Given this list of marker genes PELI1, STAP1, ECE1, SP140, SLC2A3, IER2, MYCBP2, ST6GAL1, PTP4A1, CDC42SE1, PLCG2, IRS2, TMEM131L, IGHM, LYST, CD79B, MS4A1, PDLIM1, ARHGAP25, ZFP36L1, CHMP7, NT5E, NR4A2, DGKD, RASGRP3, DUSP1, IGKC (NCBI Gene Id 3514), ABLIM1, FCMR, IGLJ3, CCR6, GSAP, PMAIP1, YBX3, TRIO, TTC9, MKNK2, BACH1, ALOX5, LIMD2, EVL, CLEC2D, BACH2, MTSS1, HLA-F-AS1, APOL3 (NCBI Gene Id 80833), HMGB2, IGHD, TAF1D, SWAP70, EIF1B, MRGBP, ADAM28, MSN, BCL2, RYK, MBD4, PARP12, AIM2, SP140L, PIK3C2B, HES1, HLA-F, PAX5, TUBA4A, MACF1, JUNB, BACE2 (beta-secretase 2), SYPL1, HK2, P2RX5, CD69, HIF1A, ATP2B1, BTG1, NOC3L, IGLV1-44, RAB8B, PLAAT4 (NCBI Gene Id 5920), NCK2, CD48, IFT57, MYC, FAM111A, PAPOLA, RESF1, DDIT3, PIK3IP1, DPEP2, LAT2, PRDM2, ZNF318, BANK1, SCPEP1, SHMT2, RAB30, IL4R (interleukin 4 receptor), PPFIBP2, IGKV3-20, SMCHD1, TUBA1A, RHOH, BCL2A1, ADD2, WWC3, PKIG, EZR, KLHL2, CD22, LY86 (NCBI Gene Id 9450), RAB29, FCER2 (NCBI Gene Id 2208), NLRP1, ISG20, PHTF2, CD72, RRAS2, KCNA3, FOXO1, CXCR5, TRAF5, GVINP1, CDKN1B, LAPTM5, CD37, CD83, TNFRSF13B, QRSL1, IL24, CD79A, BASP1, TENT5C, TRAK2, PDK1, EIF2AK3, P2RY10, PTPRC, KLF7, HLA-DOB (NCBI Gene Id 3112), CHST2, SYNPO, TANK, PLEKHF2, IER5, CD55, SIPA1L3, CKAP2, PWP1, RHOB, FCGR2C, JUN, CDC42EP3, TBL1X, RASA3, SLC35F2, BMP2K, ELF1, IGHG1, PPP1CC, SP100, ARID5B, CDK14, CHD7, FCGR2B, MARCKS, MMD (NCBI Gene Id 23531), USP6NL, NFKBIA, ADAM8, TPD52, FCRL2, PTPN12 (NCBI Gene Id 5782), SH3BP5, ARHGDIB, CR1, LINC00623, CD24, CD19, KDM7A, TSC22D3, TRIB2, KLF2, PLEKHA2, IGKV1D-13, BIRC3, POU2AF1, ABCB4, UBXN1, PIKFYVE, EGR1, SNX2, BMS1P20, TXNIP, CEMIP2, ICAM3, CLIC4, here is a description of the gene set: Human Gene Set: GSE29618_BCELL_VS_PDC_UP species: Homo sapiens Genes up-regulated in comparison of B cells versus plasmacytoid dendritic cells (pDC). from publication Nakaya HI, Wrammert J, Lee EK, Racioppi L, Marie-Kunze S, Haining WN, Means AR, Kasturi SP, Khan N, Li GM, McCausland M, Kanchan V, Kokko KE, Li S, Elbein R, Mehta AK, Aderem A, Subbarao K, Ahmed R, Pulendran B (PMID 21743478) Systems vaccinology has emerged as an interdisciplinary field that combines systems wide measurements and network and predictive modeling applied to vaccinology. Here we used the systems vaccinology approach to study the molecular mechanisms underlying th